The following is a description of a gene set: Information on gene alterations associated to poorly differentiated (PDTC) and anaplastic thyroid carcinomas (ATC) is scarce. Using human cancer cell lines as a tool for gene discovery, we performed a cytogenetic and oligo-array analysis in five new cell lines derived from two PDTC and three ATC. In PDTC we evidenced, as important, the involvement of the MAPK/ERK kinase pathway, and downregulation of a group of suppressor genes that include E-cadherin. In ATC, downregulation of a specific group of oncosuppressor genes was also observed. Our ATC cell lines presented chromosomal markers of gene amplification, and we were able to identify for the first time the nature of the involved amplicon target genes. We found that the main molecular differences between the two cell line types were related to signal transduction pathways, cell adhesion and motility process. TaqMan experiments performed for five amplicon target genes and for two genes, which allowed a clear distinction between ATC and PDTC: CDH13 and PLAU corroborated array results, not only in the cell lines, but also in an additional set of primary 14 PDTC and three ATC. We suggest that our findings may represent new tools for the development of more effective therapies to the hitherto untreatable ATC. from publication Rodrigues RF, Roque L, Krug T, Leite V (PMID 17406368) species: Homo sapiens Human Gene Set: RODRIGUES_THYROID_CARCINOMA_ANAPLASTIC_DN Genes down-regulated in anaplastic thyroid carcinoma (ATC) compared to normal thyroid tissue., and this is the list of marker genes: NIPSNAP3B, MAML3, ATP6V0E2, NF1, CRTC3, TMEM171, PARM1, DCAF8, SLC25A29, DDX25, MAMDC2 (MAM domain containing 2), GSTM3, PLPP3, TEF, OFD1, AKAP13, TBC1D24, GABPB2, EDNRB, WFS1, GPM6A (glycoprotein M6A), ZNF518A, HOOK3, FRY, KCTD12, DEPTOR, SLC17A5, TULP4, ST3GAL5, KIZ, SDF2L1, RXRA, FBXO21, TEX264, MRPL54, ACOX1 (acyl-CoA oxidase 1), ZCCHC24, PEBP1, MIA3, ZBTB20, ABTB3, GSTM1, NEBL, CREB3L2, USP54, FEZ1, UBE2D3, SLC35D2, FOXO1, RBPMS, RNPC3, TACC2, PRKX, SULT1A3, FAM83F, ENO3, BDH2, TOB1, N4BP2L2, CALM1, SPTBN1, TENT5C, AOPEP, SYNPO2, LONP2, PCBP2, MAP3K1, SLC5A3, MSRB2, FAM110B, SMCO4, FAM53B, ATP5IF1, SLC39A14, TNS1, GUSBP14, MAN1A1, NDFIP1 (Nedd4 family interacting protein 1), LINC01140, HIRA, C16orf46, NDUFA5, PTPRD, HDHD2, NME7, SDC2 (syndecan 2), ADGRA2, SORD, TCTN1, PTPRB, RIMKLB, ARHGEF40, PURA, PARP8, SLC25A23, ALDH9A1, AKAP12, CPQ, COX20, MEF2C, ITGA1, MTURN, GSTP1 (glutathione S-transferase pi 1), ECHDC3, POLI, SNX1, TBX3, LRRC37A2, NEDD9, ZNF706, NSUN4, GALNT11, FOS, EVA1C, MT1F, TPST2, ZFHX3, FAM66A (NCBI Gene Id 552864), LHFPL6, RILPL2, KLHL41, ECM2, PYM1, SHANK2, ARHGAP31 (NCBI Gene Id 57514), STXBP6, CYB5D2, RNASET2, ZNF573, NFATC3, BORCS7 (NCBI Gene Id 119032), LIFR, PAX8, C8orf88, HSP90B1, SMAD9 (NCBI Gene Id 4093), ZC2HC1A (zinc finger C2HC-type containing 1A), IPO5P1, MYL4, GRK5, HEIH, ANKRD6, CAMK1D, AAK1, SPRING1, SERF2, HEY1, FKBP11, AMY1A, CBX7, BCL2, MAGEH1, GPD1L, PFKFB2, RRAGD, NKAPD1, MRPS6, EMC10, C22orf39, ASB5, EIF1AX, IL17D, FAM13A, CSGALNACT1, SLC25A15, MYLIP, SRRD, RASSF9 (Ras association domain family member 9), PDSS2, INAFM2, CLDN23, CEBPD (CCAAT enhancer binding protein delta), SLC44A1, FHDC1, ID1, SNX22, OR2A20P, SNTB2, FMOD, ICA1L, RALGAPA2, SULT1A2, COL14A1 (collagen type XIV alpha 1 chain), MTFR1L, PTPN11, ZFAND4, ACAA1, SERTM1, NISCH, AGPAT3, PDLIM5, CERK, CCDC18-AS1 (CCDC18 antisense RNA 1), TCF4, TBC1D1, MEIS3P1, SH3BGRL, CLN8-AS1, EIF4EBP3, FNBP1, MMRN2, DCAF17, ARID1B, IFTAP, SLC16A4, KCNAB1, MLLT3, NEO1, DENND6A, NT5C3B, LOXL4, MSI2, ZBED3, TFF3, WASF3, KLHDC1, PABIR1, RRBP1, ZBED5-AS1, TMF1, SNRPA1, TCTA, SNHG5, SLC6A13, AGTR1, RASSF5, CSRNP3, GPX3, ABAT, ENPP1, MROH1, RASSF8-AS1, FGF7 (NCBI Gene Id 82955), PRAG1, CD302, KIAA1671, SNN, GLT8D2, ASMTL, SNRPN, UST, GSTA4, GSPT1, PINK1, SPRY4-AS1, ACTA2, MAGI2, SAP30BP, RMDN1, KIAA1217, EGR1 (NCBI Gene Id 1958), EPB41L4B, SH3RF1, TMEM64, IQCK, GPRASP2, ZFYVE21, PRKG1, CCDC80, AKAP17A, GALNT18, HERC1, GLIPR2, SMAD4, ADGRA3, CXorf38, CISD3, FBXO7, CPE, CRYL1, CYB5R1, AKAP1 (NCBI Gene Id 8165), CLN5, CDKL1, FIP1L1, FOXE1, SLC26A4, HES1, AGO1, DGLUCY, GPM6B, PODXL, RERE, KBTBD7, HGSNAT, SYNE2, HDAC11, TMEM67, TIMP3, FYCO1, ABCA5, TMEM178A, ST6GALNAC3, TOM1L2, KLF9, SESN1, ELF2, ECHDC2, STRBP, DDHD2, DMBT1, GOLGA8N, GNAQ, SMAD1, ANKRD46, MPZL2, ARHGAP6, C11orf71, ZBTB47 (zinc finger and BTB domain containing 47), ABI3BP, KANSL1-AS1, ST3GAL1, ABHD14A, RNF170, SORL1, ARHGAP42 (NCBI Gene Id 83935), NSD1, ZMIZ1, HLA-DPA1, PRKAR1A, MXRA7, SASH1, BRWD1, TMEM116, PKIA, ATOH8, NR4A2, PSD4, RBMS3, ATP9B, PNKD (PNKD metallo-beta-lactamase domain containing), LRIG3, ZNF875, SLC25A27, GIT2, MTUS1, HSPA12A (heat shock protein family A (Hsp70) member 12A), CCDC28A, BBS1, NPAS3, FZD1, GPR27, VGLL4, FARP1, SLC7A8, RUFY3, MPC1, SNRK, GALK2, CYP4V2, IVD, BEX4, CCDC92, STAT5B, TMEM164, SNORD60, MCAM, CAV2, FRMD4B, KIDINS220, ZC3H6, SLC38A10, ZNF431, TMED4, PRR4, PLSCR4, FNDC1, PBX1, ITPR1, MPV17L, RFX1, SKP1, METAP2, ILVBL, GSN, LZTFL1, CYLD, FKBP7, GNAI1, CACHD1, MAGI1, BTD, ARHGAP24, BMPR1A, SLC25A4, SAMD13, ANKRD13A, BCAM, SLC18B1, CTSS, HHEX (NCBI Gene Id 5556), PITPNC1, ZMAT1, MATN2, FMNL3, NMB, AFAP1L2, NLK, IGFBP7, AKT2, SLC25A3, SGK1, SMIM19 (small integral membrane protein 19), ADGRL2, MARCKSL1, GHR, PLEKHH1, PTPRG, ZBTB37, SLC16A2 (NCBI Gene Id 6567), BANK1, TRIB1, DPY19L3, PDE4A, CPNE3, RAB18, DOK5, ARID2, TSPAN12, GNAS, H19, ZBED1, AQP3, SMDT1 (single-pass membrane protein with aspartate rich tail 1), FECH, CFH, MZF1, NEB, TNFRSF11A, AZGP1, UBR5-DT, DGKI, PHYH, GFOD3P (Gfo/Idh/MocA-like oxidoreductase domain containing 3, pseudogene), STX12, PRDM11, ARHGAP5, CSRP1, CDON, KIF9, AHCYL2, RILPL1, ZNF678 (NCBI Gene Id 84841), KCTD2, CIRBP (NCBI Gene Id 1153), ERLIN2, CDKL5, MLPH, RCAN3, LNX1, CYFIP2, RBM26-AS1, CROT, GLCCI1, LRP8, ZFP36L2 (NCBI Gene Id 96706), CHPT1, SESN3, PHACTR2, WDFY3-AS2, LRIG1, FGF13, B9D1, ARSD, ZSCAN18, CTSK, HNRNPDL, AXIN2, SLIT2 (slit guidance ligand 2), SH3BGRL2, LPCAT2, NKTR, HIGD1A, PPP1R13B, CYBRD1, SIAE, ALDH3A2, SLC66A2, TEX2, EED, EGR3, EPM2AIP1, ENY2, FTX, PKNOX1, PPP3CB, PBXIP1, CBR4, GPRASP1, CTSB, C10orf95-AS1, SCARA3, RGS5, MB, ASAH1, TMEM50B, SBSPON, FHL1, PDGFD, COX7B, PPP6C, TMEM150C, SIDT2, AP4S1, CLDN11, TRIM58 (NCBI Gene Id 25893), GLIS3, SLC4A4, KAT2B, PLA2G12A, STARD13, FAM162A, PTPN4, PCDH18, DANCR, MED13L (NCBI Gene Id 23389), EIF4E3, PLPP1, FKBP2, RAPH1, ZNF711, FOXP1, ARMCX2, ST8SIA4, STOM, PAPSS2, SSBP2, WDR72, PCDH9, TMEM25, GRAMD4, TATDN3, MAPDA, FKBP5, SULT1A1, LBH, PAPOLG, TNFRSF11B (NCBI Gene Id 4982), VWA5A, FLRT3, RNF38